The following is a description of a gene set: Patellar aplasia studied in species Homo sapiens Absence of the patella. Human Gene Set: HP_PATELLAR_APLASIA, and this is the list of marker genes: ANAPC1, RBM8A, LMBR1, ESCO2, WNT7A (Wnt family member 7A), CHRNG, CDT1, ORC1, SHOX, TBX4, ORC4, CDC6, KAT6B, STXBP1, GMNN, CDC45, BHLHA9, RECQL4, ORC6, DONSON, LMX1B, SHH